Given this list of marker genes DGAT2, MOGAT1, PPP1CC, FABP12, PLIN3, FABP9, PRKACB, FABP1, PNPLA4, PPP1CA, CAV1, ABHD5, LPIN2, PRKACG (NCBI Gene Id 5568), GK3, GPAM, LPIN1, FABP5, LIPE, FABP3, FABP2, FABP7 (fatty acid binding protein 7), AGMO, GK, MOGAT3, LPIN3, PLIN1, FABP4, MOGAT2, MGLL, GPD2, GK2, PRKACA, FABP6, PPP1CB, PNPLA5, DGAT1, GPAT2, here is a description of the gene set: studied in species Homo sapiens Fatty acids derived from the diet and synthesized de novo in the liver are assembled into triglycerides (triacylglycerols) for transport and storage. Synthesis proceeds in steps of conversion of fatty acyl-CoA to phosphatidic acid, conversion of phosphatidic acid to diacylglycerol, and conversion of diacylglycerol to triacylglycerol (Takeuchi & Reue 2009).<br>Hydrolysis of triacylglycerol to yield fatty acids and glycerol is a tightly regulated part of energy metabolism. A central part in this regulation is played by hormone-sensitive lipase (HSL), a neutral lipase abundant in adipocytes and skeletal and cardiac muscle, but also abundant in ovarian and adrenal tissue, where it mediates cholesterol ester hydrolysis, yielding cholesterol for steroid biosynthesis. The hormones to which it is sensitive include catecholamines (e.g., epinephrine), ACTH, and glucagon, all of which trigger signaling cascades that lead to its phosphorylation and activation, and insulin, which sets off events leading to its dephosphorylation and inactivation (Kraemer & Shen 2002).<p>The processes of triacylglycerol and cholesterol ester hydrolysis are also regulated by subcellular compartmentalization: these lipids are packaged in cytosolic particles and the enzymes responsible for their hydrolysis, and perhaps for additional steps in their metabolism, are organized at the surfaces of these particles (e.g., Brasaemle et al. 2004). Reactome Pathway: Triglyceride metabolism part of: Metabolism of lipids